Given this list of marker genes SCARB1, APOB, APOA1, SAA1, SSC5D, CD36, here is a description of the gene set: Human Gene Set: REACTOME_SCAVENGING_BY_CLASS_B_RECEPTORS Scavenging by Class B Receptors species: Homo sapiens